Given this list of marker genes Apoa1, Enpp7, Abcg5, Lpcat3, Apoa2, Cyp8b1, Apoa4, Lep, Abcg8, Acat2, here is a description of the gene set: Any process that modulates the frequency, rate or extent of absorption of cholesterol into the blood, and the exclusion of other sterols from absorption. species: Mus musculus Mouse Gene Set: GOBP_REGULATION_OF_INTESTINAL_CHOLESTEROL_ABSORPTION